The following is a description of a gene set: Human Gene Set: GOBP_DEOXYRIBONUCLEOSIDE_MONOPHOSPHATE_BIOSYNTHETIC_PROCESS The chemical reactions and pathways resulting in the formation of a deoxyribonucleoside monophosphate, a compound consisting of a nucleobase linked to a deoxyribose sugar esterified with phosphate on the sugar. species: Homo sapiens, and this is the list of marker genes: DUT, SHMT1, DCTD, ADK, TK2, DCK, DGUOK, TYMS, TK1